Given this list of marker genes Nrcam, Cd200r1, Cd47, Cd200, Nfasc, Gldn, Cxadr, Sirpa, Izumo1, here is a description of the gene set: Mouse Gene Set: GOMF_PROTEIN_BINDING_INVOLVED_IN_HETEROTYPIC_CELL_CELL_ADHESION species: Mus musculus Binding to a protein or protein complex contributing to the adhesion of two different types of cells.